Given this list of marker genes Tal1, Pax6, Nfib, Hes5, Sox6, Ctnnb1, Nkx2-2, Nrg1, Ntf3, Nfia, Smarca4, Ascl1, Sox8, Olig2 (NCBI Gene Id 50913), Nfix (NCBI Gene Id 18032), Gcm1, Nfe2l1, Sox9, here is a description of the gene set: Mouse Gene Set: GOBP_GLIAL_CELL_FATE_COMMITMENT The process in which the developmental fate of a cell becomes restricted such that it will develop into a glial cell. studied in species Mus musculus